The following is a description of a gene set: from publication Rubenstein AB, Smith GR, Raue U, Begue G, Minchev K, Ruf-Zamojski F, Nair VD, Wang X, Zhou L, Zaslavsky E, Trappe TA, Trappe S, Sealfon SC (PMID 31937892) Human Gene Set: RUBENSTEIN_SKELETAL_MUSCLE_T_CELLS species: Homo sapiens, and this is the list of marker genes: FYB1, RPS27, CD7, RPL7A, RACK1, EIF1, RPL10, CD2 (CD2 molecule), TSC22D3, EIF2S2, LAPTM5, RPL27A, IER2, CD48, RPS3A (NCBI Gene Id 6189), RPL8, RPL11, RPL35A, TMEM123, FAU, RPL18, EIF3E, ACTR3, CD3G, RPL22, NOSIP, NPM1, CUTA, RPL15, RPL24, CXCR4, RPS14, PLP2, RPL36A (ribosomal protein L36a), HSPA8, CORO1A, RPSA, RPL27, LIMD2, HMGN1, RPL14, RPS28, SNHG8, RPS3 (ribosomal protein S3), RPLP0, ZFAS1, RPS16, GMFG, RPL23, RPS4Y1, CD44, ZFP36L2 (NCBI Gene Id 96706), RPL34, RPS15A, RPS4X, SERP1, HINT1, RPS20, RPL6, RPS2, TMSB4X, COX7C, SLFN5, RPL19, RPL23A, RPL32, PPP2R5C, RPL28, SH3BGRL3, PFDN5, RPL18A (NCBI Gene Id 6142), CD69, JUNB, HCST (hematopoietic cell signal transducer), NOP53, TPT1, CDC42SE1, RPL26, BTF3, RPS18, RPS9, TRAF3IP3, TOMM7, RPL29, UQCRB, ARPC1B, RPS12, LEPROTL1, UBE2D2, RPS5 (ribosomal protein S5), RPS27A, EEF1B2, SNHG32, RPS26, CD52, ATP5MG, UBA52 (NCBI Gene Id 7311), IL32, ERP29, RPS23, RPL30, ABRACL, RPLP1, RPL36 (ribosomal protein L36), UXT, ETS1, IL7R, RSL1D1, RPS21, PTPRC, OST4, CD3E, RPL5, PRKCQ-AS1, RPS29, RPL39, RPSA2, EIF3D, ARL6IP5, RPL17 (ribosomal protein L17), CRIP1, RPS19, EVL, CD3D, COMMD6, RPS6, RPL12, RPL13, APRT, EIF3F, PTPRCAP, FXYD5, IL2RG, RPL7, LCK, SELL, PABPC1, BTG1, RPS15, EEF1A1 (eukaryotic translation elongation factor 1 alpha 1), RPL13A, EMP3, ARHGDIB, EIF3L, RPL4, RPS24, COTL1, RPL31, PLAC8, PPP1R2, RPS13, ISG20, RPL35, TMA7, RPL3, LDHB, CD37, SARAF, RPL10A, RPS7, RPS25 (NCBI Gene Id 6230), HNRNPA1, LTB, EIF3H, RPL36AL, C1orf56, CYBA, RSL24D1, RPL41, PFN1 (profilin 1), EEF1D, RPLP2, RPL21, RPL37A, RPL9, RPL37, RPL38, RPS8, RPS10, GIMAP4, OCIAD2